Given this list of marker genes CIITA, PSMB9, CASP1, TNFSF13B, IFI35, TNFSF13 (TNF superfamily member 13), CD14, OAS3, TICAM2, PECAM1, XAF1 (NCBI Gene Id 54739), MYD88, SMURF2, CD86, MX1, MX2, OAS1, IL10RB, PSMB10, PLSCR1, IRF7, IRF5, TRIM22, CTSB, TLR7, OAS2, STAT2, UNC93B1, TLR8, STAT1, JAK2, TNFSF10, here is a description of the gene set: from publication Nakaya HI, Wrammert J, Lee EK, Racioppi L, Marie-Kunze S, Haining WN, Means AR, Kasturi SP, Khan N, Li GM, McCausland M, Kanchan V, Kokko KE, Li S, Elbein R, Mehta AK, Aderem A, Subbarao K, Ahmed R, Pulendran B (PMID 21743478) species: Homo sapiens Genes up-regulated in peripheral blood mononuclear cell 3d vs 0d in adults (18-50) after exposure to FluMist, time point 3D. Comment: Molecular signature induced by LAIV vaccination. (a) Interferon (IFN)-related genes differentially expressed after LAIV vaccination Human Gene Set: NAKAYA_PBMC_FLUMIST_AGE_18_50YO_3DY_IFN_SUBSET_UP Here we have used a systems biology approach to study innate and adaptive responses to vaccination against influenza in humans during three consecutive influenza seasons. We studied healthy adults vaccinated with trivalent inactivated influenza vaccine (TIV) or live attenuated influenza vaccine (LAIV). TIV induced higher antibody titers and more plasmablasts than LAIV did. In subjects vaccinated with TIV, early molecular signatures correlated with and could be used to accurately predict later antibody titers in two independent trials. Notably, expression of the kinase CaMKIV at day 3 was inversely correlated with later antibody titers. Vaccination of CaMKIV-deficient mice with TIV induced enhanced antigen-specific antibody titers, which demonstrated an unappreciated role for CaMKIV in the regulation of antibody responses. Thus, systems approaches can be used to predict immunogenicity and provide new mechanistic insights about vaccines.